The following is a description of a gene set: species: Homo sapiens Any process that stops, prevents, or reduces the frequency, rate or extent of a defense response. Human Gene Set: GOBP_NEGATIVE_REGULATION_OF_DEFENSE_RESPONSE, and this is the list of marker genes: CD200R1, IRAK3, MVK, GHRL, MIR92A1, AOAH, FXR1, LPCAT3, PPARG, FPR2, NR1H2, CR1, PGLYRP1, FCGR2B, CNOT7, SPINK5, GIT1, IRGM, PLA2G10, MIR181C, TIGIT, PROC (protein C, inactivator of coagulation factors Va and VIIIa), CDH5, LYN, HLA-F, YES1, NT5C2 (5'-nucleotidase, cytosolic II), STAT3, GPR17, PLCG1, MIR146A, KIR2DL4, PPARA, MICB, IL2RA, MIR26A1, NFKB1, EXTL3, REG3A, GPER1, APOE, DSG2, PARP14, NT5E, TTLL12, GPX1, MDK, PPP1R13L, SLAMF8, KLRC1, RHBDF2, MIR15A, C1QBP, MIR19B1, MIR199A1, CX3CL1, HLA-B, ADIPOQ, NLRP4, PPARD, SUSD4, GSTP1, IL20RB, MMP26, AURKB, IER3, ARRB2, BCR (NCBI Gene Id 729775), BANF1, LILRB1, PTGIS, MIR3909, OAS1, METRNL, IFI16, SLC39A8, TNFAIP6, IL13, MIR205, CD200, APCS, FYN, ARG1, TRIM45, VSIG4, DRD2, MIR30C2, IL22, GNAS, SMAD3, PPM1B, TGFB1, TRIM21 (tripartite motif containing 21), NR1H4, ITCH, C1QTNF3, FFAR4, GBA1, IGF1, ARG2, MICA, ALOX5, NR1H3, HAVCR2, MIR590, SAA1, MKRN2, MIR181A2, LYAR, MIR223, NLRX1, TRAF3IP1, SERPINB9, GRN, KRT1, VPS35, FGL2 (fibrinogen like 2), ISG15, PTPRC, YTHDF3, USP38, FAM76B, PRKCD, MIR195, CEACAM1, NR5A2, TREX1, ZDHHC18, TRAFD1, USP15, HLA-G, MAPK14, DDX39A, FGR, GHSR (growth hormone secretagogue receptor), GRB2, CYLD, CST7 (NCBI Gene Id 8530), FEM1A, TEK, STAT2 (signal transducer and activator of transcription 2), PTGER4, APOA1, RABGEF1, UACA, YTHDF2, NLRC5, IL4, HCK, PTPN2, HLA-E, NECTIN4, TNFRSF1A, MAPK7, MIRLET7G, ASH1L, MIR19A (NCBI Gene Id 406979), CYP19A1, SELENOS, MIR920 (microRNA 920), OTOP1, MIR302E, SIGLEC10, ATG12, MACIR, SBNO1, TNFAIP3, PBK, ILRUN, SOCS5, GPR31, NLRP6, OTULIN, METTL3, ELF4, FURIN (furin, paired basic amino acid cleaving enzyme), PSMB4, ISL1, INPP5D, EIF4E2, MIR149, MUL1, HGF, ADORA1, ADORA2A, SOCS3, MIR181B1, DHX58, PYDC2, IL22RA1, ADA, MIR221, DTX4, HLA-A, ATG5, FAM3A, CXCL17, SPN, TNFRSF1B, GPS2, SYK, ARNT (NCBI Gene Id 405), TREM2, SMPDL3B, TNFAIP8L2, HLA-DRB1, CLEC12A, IL17A (interleukin 17A), NECTIN2, AHR, USP18, MIR4286, MAPKBP1, TRIM38, RPS19, NMI (N-myc and STAT interactor), LGALS9, SMIM30, ACP5, YWHAZ, MIR16-1, KLF4, PVR, LRFN5, CRK (CRK proto-oncogene, adaptor protein), NDFIP1, IL33, IL10RA, CEP63, MIR6869, IL12B, MIR15B, MIR21, IL10, MIR222, CACTIN, MIR488, TMSB4X, MIR4691, NLRC3, C1QTNF12, SAMHD1, MIR20A, A2M, PIM1, CLEC12B, ACOD1, ENPP3, FOXF1, CD96, MIR187, NPY5R, GATA3, FNDC4, SFN (stratifin), DUSP10, SOD1, PCBP2, MIR105-1, PTPN6, SIRPA, MIR31, NPY, RORA, PSMA1, RB1, MIR145, FOXP3, SHARPIN, MIR138-1, INS, RNF26, PLK2, GIGYF2, MMP12, SERPING1, TARBP2, MEFV, TRIM65, MIR141, MIR26B, SERPINB4, NR1D2, TAFA3, SYT11, MIR766, SRC, LDLR, MFHAS1, NLRP3, ELANE, MIR142, ADAR, OAS3, NR1D1, WFDC1, TYRO3, MIR204, PARP1, DNAJA3, IL2, IL22RA2, KLRD1, DCST1, NLRP12, CCN3